Given this list of marker genes IFIT3, KPNA6 (karyopherin subunit alpha 6), YIPF4, ACAD9, MAPK6, ICAM1, MIS18A, PAN2, LRIG3, RETREG3, HELB, PAG1, GOLPH3L, VEZT, TMEM144, RO60, NIPAL3, IFI6, DCP2, LPP, NOL4, SLC16A4, SNRK, SMIM14, SERINC3, SLC10A7, KLHL12, MFSD1, PAAF1, ZDHHC12, SLC39A8, TNFAIP3, B4GALT6, LANCL1, LRP1B, TPP1, ISL1, SNX11, PANK1, RARB, GNPDA1, CLIP4, IREB2, CD2AP, SLC35E3, PARM1, PPP3CA, CCNG2, FZD6, GNAI3, G6PC3, COX15, PUDP, MICU1, TAFA2, RPS12, ANAPC1, MRGPRX3, NGLY1, RAP2C, TNFRSF9, ETNK1, CTSD, PAFAH2, OPTN, MPV17, ACSS3, APBB3, EGF, TMBIM1, NEU1, FAM91A1, GOLGA3, FCHSD2, GPR137B, H1-0, BVES, ICAM2, FRK, RUSF1, SESN3, CLU, DCAKD, TIGD1, PSMD5, SOX6, ARK2N, IFT46, NECAP1, ARAP1, ATP10D, IL1RAP, AMDHD2, SIDT2, NIT1, HMOX2, TCTA, RNF168, DIDO1, ANKS1A, SEMA3A, S100PBP, STRA6, CCDC25, DNAJC16, TM7SF3, API5, STYXL1, GTPBP2, RPRD1B, DDI2, KLHL24, PCMTD1, TPM3, LIPH, LIN7C, CMTR1, ENPP1, UNKL, MFSD14B, CSRNP3, STX4, PHKB, BST2, PEX16, SHPK, SARAF, DCAF17, C2CD2, SERINC1, UBE4B, MAPDA, TAF10, CSNK1D, OAS1, PITX2, PSMB9, MVP (NCBI Gene Id 9961), NFKB2, VPS36, NAGK, LRRC37A, CBR4, MED16, CCNDBP1, M6PR, BIRC2, PCYT1A, OTUD4, STAT6, TMED8 (transmembrane p24 trafficking protein family member 8), CLCN7, OXNAD1, RBM47, BMI1, PLSCR4, FGD6, ATP6V0D1, COG5, FOXRED1, CEP57, MOCS2, ELAVL1, IL32, ACSL4, PIK3CB, PBXIP1, ARL6IP1, SKP2, MLC1, PDE1A (NCBI Gene Id 5136), TDRKH, KLHL18, CTC1, ZFYVE26, COL5A2, DUSP3, CGGBP1, TMEM179B (NCBI Gene Id 374395), OSBPL8, NHLRC2, ABHD4, TOR1B, RXFP2, RMND5B, BTN3A1, MR1, SLC9A8, FGGY, CLCN3, UROS, ACTA2, KLHL28, ATP6V1A, SLFN5, ARL5B, STAT1, TOP1P1, SDE2, ARL1, CALCRL, CYB561A3, PIP4K2C, MIF4GD, SLC33A1, NFKBIZ, MYEF2, GPM6A, SGCZ, RECQL5, BIRC3, ZBTB41, ARMCX1, HERC6, TMEM127, STK38L, CHUK, INSIG1, LIPI, LCP1, APOBEC3D, RNF141, CYB5D2, NKIRAS2, RBCK1, TMEM164, RPIA, WEE1, JKAMP, PIGO, EPDR1, TBC1D13, RAB8B (RAB8B, member RAS oncogene family), TACC1, IRF9, SUN2, SHKBP1, CCL18 (NCBI Gene Id 6362), CLIC2, ELMOD2, PTCD2, COL1A2, TRAPPC14, TBCEL, DCAF12 (DDB1 and CUL4 associated factor 12), BMAL1, RASA1, INSIG2, CASP8, MTMR14, ECH1, TKFC (NCBI Gene Id 26007), FAM199X, OAS3, TSPAN31, C6orf58, TDG, BPGM, KLHDC10, FLVCR1-DT, RAPGEF2, IFI35, ZDHHC4, TMEM63A, N6AMT1 (NCBI Gene Id 29104), DBNL, KPNA5, GPRC5A, BCL2L13, COL3A1, NSRP1, AGPAT3, RWDD2B, SLC7A11, TSPYL5, SQSTM1, SGK1, SP100, PGAP2, ITGA1, RSC1A1, ARHGAP19, FAM234A, WNT10A, EXD2, RRAGC, SLC20A2, IL7R, PCMTD2, TBC1D7, SPRYD3, PPCS, AZIN1, TMEM175, PGM2L1, DDX60L (NCBI Gene Id 91351), IFIT1, ZFYVE1, SOAT1, PLEKHA1, PIGS, GADD45G, CPEB4, KATNAL1, DHX58, APAF1, GOLT1B, DSG3, IVD, CHEK1, CREBL2, SPRTN, IFIT2, CCZ1, here is a description of the gene set: studied in species Homo sapiens Genes down-regulated in A4573 cells (Ewing's sarcoma, ESFT) after knockdown of BMI1 by RNAi. from publication Douglas D, Hsu JH, Hung L, Cooper A, Abdueva D, van Doorninck J, Peng G, Shimada H, Triche TJ, Lawlor ER (PMID 18701473) Deregulation of the polycomb group gene BMI-1 is implicated in the pathogenesis of many human cancers. In this study, we have investigated if the Ewing sarcoma family of tumors (ESFT) expresses BMI-1 and whether it functions as an oncogene in this highly aggressive group of bone and soft tissue tumors. Our data show that BMI-1 is highly expressed by ESFT cells and that, although it does not significantly affect proliferation or survival, BMI-1 actively promotes anchorage-independent growth in vitro and tumorigenicity in vivo. Moreover, we find that BMI-1 promotes the tumorigenicity of both p16 wild-type and p16-null cell lines, demonstrating that the mechanism of BMI-1 oncogenic function in ESFT is, at least in part, independent of CDKN2A repression. Expression profiling studies of ESFT cells following BMI-1 knockdown reveal that BMI-1 regulates the expression of hundreds of downstream target genes including, in particular, genes involved in both differentiation and development as well as cell-cell and cell-matrix adhesion. Gain and loss of function assays confirm that BMI-1 represses the expression of the adhesion-associated basement membrane protein nidogen 1. In addition, although BMI-1 promotes ESFT adhesion, nidogen 1 inhibits cellular adhesion in vitro. Together, these data support a pivotal role for BMI-1 ESFT pathogenesis and suggest that its oncogenic function in these tumors is in part mediated through modulation of adhesion pathways. Human Gene Set: DOUGLAS_BMI1_TARGETS_DN